Given this list of marker genes SLC10A1, FXR1, SLC10A2, FGF19, MAPK1, LDLR, CYP7A1, ABCB11, MAPK3, ABCG5, FGFR4, ABCG8, here is a description of the gene set: Bile acid synthesis and enterohepatic circulation studied in species Homo sapiens Human Gene Set: WP_BILE_ACID_SYNTHESIS_AND_ENTEROHEPATIC_CIRCULATION